The following is a description of a gene set: Human Gene Set: HP_ABNORMAL_BLADDER_MORPHOLOGY Abnormal bladder morphology studied in species Homo sapiens Any structural anomaly of the bladder., and this is the list of marker genes: LAMB3, KRAS, COL5A1, NCF1, MYRF, SLC35A2, CC2D2A, G6PC3, LAMC2, CCNQ, COL3A1, FOXF1, LRIG2, FREM2, DNAJC30, COL1A2, RAC2, ROBO1, UPB1, PLOD1, PIGN, ISL1, SMAD3, TMEM270, COL5A2, ACTG2, ITGB4 (integrin subunit beta 4), NKX2-1, ITGA6, SALL4, ELN, MYH11, TP63, MLXIPL, MYL9, AQP2, STX1A, MKS1, GTF2IRD2 (NCBI Gene Id 84163), NDUFB8, BUD23, LMOD1, MED12, TBL2, LTBP4 (NCBI Gene Id 8425), CLIP2, VPS37D, METTL27, EIF4H, POR, LAMA3, WNT4, MKKS, LTBP1, ALDH18A1, FBLN5, ALG9, MBTPS2, RFC2, CDH11, COL1A1, EFEMP1, ATP7A, PAH (phenylalanine hydroxylase), GTF2IRD1, FKBP14, MYLK, BAZ1B, STK11, GRIP1, FKBP6, EFEMP2, AVPR2, LIMK1, GTF2I, PLEC, MYOCD (myocardin)